The following is a description of a gene set: part of: Dopamine clearance from the synaptic cleft Alternately dopamine is metabolized to homovanillic acid in a two-step reaction in which dopamine is first oxidized to 3,4-dihydroxypheylacetic acid (DOPAC) and then converted to homovanillic acid by catecholamine o-methyltransferase. species: Homo sapiens Reactome Pathway: Enzymatic degradation of Dopamine by monoamine oxidase, and this is the list of marker genes: COMT, MAOA